The following is a description of a gene set: species: Homo sapiens Reduction of cytosolic Ca++ levels Human Gene Set: REACTOME_REDUCTION_OF_CYTOSOLIC_CA_LEVELS, and this is the list of marker genes: ATP2A1, SLC8A3, ATP2B2, ATP2A2, ATP2A3, SRI, ATP2B4 (ATPase plasma membrane Ca2+ transporting 4, NCBI Gene Id 54594), ATP2B1, ATP2B3, SLC8A1, CALM1, SLC8A2